The following is a description of a gene set: species: Homo sapiens Reactome Pathway: OAS antiviral response part of: Antimicrobial mechanism of IFN-stimulated genes The human oligoadenylate synthetase (OAS) family consists of four proteins whose production is stimulated by interferon, OAS1, OAS2, OAS3, and OASL. The first three members have the 2'-5'-oligoadenylate synthetase activity for which the family is named (Sadler AJ & Williams BR 2008), whereas OASL is devoid of this activity despite sharing significant sequence similarity with the other OAS proteins (Zhu J et al. 2015). OAS1, 2, and 3 are activated by double-stranded RNA to synthesize 5'-triphosphorylated 2'-5'-oligoadenylates (2-5A) from ATP (Kerr IM & Brown RE 1978). The 2-5A serve as chemically unique second messengers that induce regulated RNA decay by activating ribonuclease L (RNase L), thus mediating antiviral innate immunity (Zhou A et al. 1993; Lin RJ et al. 2009; Huang H et al. 2014; Han Y et al. 2014). RNase L has also been implicated in antibacterial innate immunity (Li XL et al. 2008). RNase L cleaves single-stranded RNA (ssRNA) in U-rich sequences, typically after UU or UA dinucleotides leaving a 5'-OH and 2',3'-cyclic phosphate (Floyd-Smith G et al. 1981; Wreschner DH et al.1981; Cooper DA et al. 2014).<p>Some OAS proteins have additional or alternative antiviral functions that are independent of RNase L activity (Perelygin AA et al., 2002; Kristiansen H et al. 2011). The precise mechanisms of RNase L-independent OAS antiviral activities remain to be fully elucidated., and this is the list of marker genes: OAS1, FLNA, OAS3, VP3, RIGI, Human respiratory syncytial virus A2, complete genome, OASL, RNASEL, PDE12, OAS2, ABCE1